The following is a description of a gene set: studied in species Mus musculus from publication Cui A, Huang T, Li S, Ma A, Pérez JL, Sander C, Keskin DB, Wu CJ, Fraenkel E, Hacohen N (PMID 38057668) Cytokines mediate cell-cell communication in the immune system and represent important therapeutic targets. A myriad of studies have highlighted their central role in immune function, yet we lack a global view of the cellular responses of each immune cell type to each cytokine. To address this gap, the authors created the Immune Dictionary, a compendium of single-cell transcriptomic profiles of more than 17 immune cell types in response to each of 86 cytokines (>1,400 cytokine-cell type combinations) in mouse lymph nodes in vivo. A cytokine-centric view of the dictionary revealed that most cytokines induce highly cell-type-specific responses. For example, the inflammatory cytokine interleukin-1β induces distinct gene programmes in almost every cell type. A cell-type-centric view of the dictionary identified more than 66 cytokine-driven cellular polarization states across immune cell types, including previously uncharacterized states such as an interleukin-18-induced polyfunctional natural killer cell state. Mouse Gene Set: CUI_CDC1_IL4_RESPONSE_UP Genes positively differentially expressed in cell type: cDC1 (conventional dendritic cell type 1) upon treatment with cytokine: IL-4 in mouse lymph nodes in vivo., and this is the list of marker genes: Denr, Plbd1, Hfe, Apol7c, Cycs